The following is a description of a gene set: studied in species Homo sapiens from publication Hoek KL, Samir P, Howard LM, Niu X, Prasad N, Galassie A, Liu Q, Allos TM, Floyd KA, Guo Y, Shyr Y, Levy SE, Joyce S, Edwards KM, Link AJ (PMID 25706537) Genes up-regulated in B cell 1d vs 0d in adults after exposure to 2011-2012 trivalent inactivated vaccine (A/California/7/09 (H1N1), A/Perth /16/2009 (H3N2), B/Brisbane/60/2008), time point 1D. Comment: Up-regulated DE RNA transcripts (up >= 1.5x) shared between both TIV-vaccinated donors Human Gene Set: HOEK_B_CELL_2011_2012_TIV_ADULT_1DY_UP Systems biology is an approach to comprehensively study complex interactions within a biological system. Most published systems vaccinology studies have utilized whole blood or peripheral blood mononuclear cells (PBMC) to monitor the immune response after vaccination. Because human blood is comprised of multiple hematopoietic cell types, the potential for masking responses of under-represented cell populations is increased when analyzing whole blood or PBMC. To investigate the contribution of individual cell types to the immune response after vaccination, we established a rapid and efficient method to purify human T and B cells, natural killer (NK) cells, myeloid dendritic cells (mDC), monocytes, and neutrophils from fresh venous blood. Purified cells were fractionated and processed in a single day. RNA-Seq and quantitative shotgun proteomics were performed to determine expression profiles for each cell type prior to and after inactivated seasonal influenza vaccination. Our results show that transcriptomic and proteomic profiles generated from purified immune cells differ significantly from PBMC. Differential expression analysis for each immune cell type also shows unique transcriptomic and proteomic expression profiles as well as changing biological networks at early time points after vaccination. This cell type-specific information provides a more comprehensive approach to monitor vaccine responses., and this is the list of marker genes: RNU6-1, RN7SK, DUSP5, PDXP, FCN1, NCAPH, IGLV10-54, SULT1A4, LINC00943, NPIPB8, ATP6V0C